Given this list of marker genes RAB21, IL1RAPL1, NEDD4L, CUL7, NEUROG3, RAPGEF2, TRPC5, LZTS1, STAU2, ITPKA, CDKL5, SEMA4D, BAIAP2, EPHB2, LRP8, DPYSL5, SLC30A1, CUX1, SKOR2, FZD4, NSMF, CAPRIN2, ANAPC2, CDKL3, CHRNA3, CUX2, CAPRIN1, ANKRD27, SS18L1 (SS18L1 subunit of BAF chromatin remodeling complex), DHX36, TNIK, RELN, DBN1, PARP6, KNDC1, SDC2, GORASP1, HDAC6, EPHA4, PQBP1, NEDD4, YWHAH, RAP2A, ARMCX5-GPRASP2, OBSL1, SARM1, EEF2K, FBXW8, TLX2, NR2E1, TRPC6, HECW2, NFATC4, PPP3CA, STK11, GPRASP3, CHRNB2 (cholinergic receptor nicotinic beta 2 subunit), CAMK2B, GSK3B, TBC1D24, ADGRB3, NUMBL (NCBI Gene Id 9253), PAFAH1B1, PTPRD, HECW1, here is a description of the gene set: Any process that modulates the frequency, rate or extent of dendrite morphogenesis. Human Gene Set: GOBP_REGULATION_OF_DENDRITE_MORPHOGENESIS studied in species Homo sapiens